The following is a description of a gene set: cGMP effects Human Gene Set: REACTOME_CGMP_EFFECTS studied in species Homo sapiens, and this is the list of marker genes: IRAG1, PDE1A, PDE10A, KCNMB4, KCNMA1, PDE9A, KCNMB1, PRKG1, PDE5A, PDE2A, KCNMB3, KCNMB2, PDE11A, ITPR1, PDE1B, PRKG2